The following is a description of a gene set: species: Homo sapiens A tissue homeostatic process involved in the maintenance of an internal equilibrium within the retina of the eye, including control of cellular proliferation and death and control of metabolic function. Human Gene Set: GOBP_RETINA_HOMEOSTASIS, and this is the list of marker genes: LCA5, CLCN3, USH1G, PCDH15, AIPL1, CDH3, CLRN1, ESRRB, SPATA7, RHO, USP45, CRB2, NXNL2, BBS12, SLC28A2, ARAP1, RPE65, CDHR1, RP1L1, ERCC6, PROM1, CCDC66, BBS2, BBS10, VSTM4, NXNL1, USH1C, CNGB1, BBS1, NPHP4, ABCA4, IQCB1, BSG, ARMS2 (age-related maculopathy susceptibility 2), CLN8, CRB1, BBS4, MAK (NCBI Gene Id 4117), MKKS, POC1B, SLC2A1, CIB2, ELP6, TUB, NPHP3, CDH23, USH2A, ADGRV1, GNAT2, RDH12, TULP1, SOD1, DRAM2, CROCC, RP1, ATP1B2, NDP, EPG5, WHRN